The following is a description of a gene set: Reactome Pathway: Defective HEXB causes GM2G2 (Hyaluronan metabolism) part of: Diseases associated with glycosaminoglycan metabolism studied in species Homo sapiens Beta-hexosaminidase (HEX) cleaves the terminal N-acetyl galactosamine (GalNAc) from glycosaminoglycans (GAGs) and any other molecules containing a terminal GalNAc. There are two forms of HEX; HEXA and B. The A form is a trimer of the subunits alpha, beta A and beta B. The B form is a tetramer of 2 beta A and 2 beta B subunits. Defects in the two subunits cause lysosomal storage diseases marked by the accumulation of GM2 gangliosides in neuronal cells.<br><br>Defects in the beta subunits are the cause of GM2-gangliosidosis type 2 (GM2G2; MIM:268800), also known as Sandhoff disease. Sandhoff disease is an autosomal recessive lysosomal storage disease clinically indistinguishable from GM2-gangliosidosis type 1, presenting early blindness with cherry-red spots on the macula, progressive motor and mental deterioration and macrocephaly. Death usually occurs by the age of 3 years., and this is the list of marker genes: HEXB